Given this list of marker genes FTL, PANK2, CP, HFE, SLC11A2, HEPH, TF, STEAP3 (NCBI Gene Id 55240), BCS1L, TFRC, CYBRD1, HJV, UQCRFS1, TFR2, HAMP, SLC40A1, FTH1, here is a description of the gene set: Iron metabolism disorders Human Gene Set: WP_IRON_METABOLISM_DISORDERS studied in species Homo sapiens